Given this list of marker genes TBC1D13, RRM2B, RUNX2, ANXA1, SYF2, VNN1, MAN1A2, MOB1B, RPS6KA2, TOLLIP, MMP14, PCARE, TSSK2, CAPN5, GPR155, P2RY14, BLOC1S4, SPTSSB, PMPCB, TNNT2, TAP1, ABI1, PAFAH1B1, TRMT112, PKP4, KCNK10, SERTAD1, ITPR1, RGL1, TANC1, FAM107B, LYSMD3, PFKP, GSPT1, MDFIC, B2M (NCBI Gene Id 567), CD82, ELOC, CAPZA1, IRF8, DENR, SAMSN1, TNIP2, SHC3 (NCBI Gene Id 53358), MYO1D, ADRB3, MTARC2, ATOSB, SPRYD7 (NCBI Gene Id 65073), FAM91A1, KAT2B, IFNAR2, MYD88, BIRC3, RILPL1, UBE2N, MTMR14, NAT2 (NCBI Gene Id 10), ATXN7L1, RAB3IP, SLF2, TSHZ1, TCP10L, SOD2, PCP4, C5orf15, DHX58, STXBP1, BRAF, JAM3, TRAF4, NDEL1, SENP6 (NCBI Gene Id 26054), SLPI, IREB2, RNF214, DUSP2, NRG3, DHPS, ALOX12, IL1RAP, SRD5A2, CGGBP1, SPTLC2, HTRA2, ASB3, MMP2, VPS54, IGF2BP1, FGL2, MSN, HMOX1, ILF3, MAGED1, WBP4, PRG4, CRIPTO, SLAMF1, RBM43, SHROOM1 (NCBI Gene Id 134549), APBB1IP, SLC40A1, USP26, SLC2A5, TRPC4AP, CARD10, POU6F1, GKAP1, BMPR1A, ZBTB37, STARD5, SLC37A3, SNX16, ATM, BST2, ADAMTS8, CHRAC1, TMEM229B, ADNP, EPGN, TENT2, FGL1 (fibrinogen like 1), PTPRA, TMEFF1, PDK3, PRPF38A, SORCS2, TMED7, SLC6A4, DLG5, TP73, WASHC4, SIN3A, GCG, OAZ2, HMGN5, GNA13, SPTB, HES5, METTL6, TNNI1, SLC26A8, DUSP16, EPX (eosinophil peroxidase), MAP3K8, G3BP2, STAT5A, LZTFL1, SPATA4, SOX12, PI4K2A, UBAP1, HIPK1, OPN4, GCA, OAS2, MAP3K5, HDAC1, GBP4, VAMP3, TSC22D1, TAMALIN, C19orf12, LDHC, DCAKD, FIS1, ARNT, GK, WDR43, CMTR1, ATXN7L3, NHERF1, SLC32A1, TMEM192, PHLDB2, SLC17A1, ANXA5, SLAMF8, TAB3, NECTIN2, EPSTI1, TRAF5, CXCL6, CCNA1, INSM1, GSAP, GTPBP2, PPP1CB, SMC5, DDA1, MLLT6, ZNF689, RNF34, AOPEP, ATL3, TMEM175 (transmembrane protein 175), MITF (melanocyte inducing transcription factor), IER5, CPD, here is a description of the gene set: species: Homo sapiens mouse primary BMDCs were stimulated with tlr ligands and gene expression changes were profiled on Affymetrix arrays Human Gene Set: GSE17721_0.5H_VS_8H_LPS_BMDC_DN Genes down-regulated in comparison of dendritic cells (DC) stimulated with LPS (TLR4 agonist) at 0.5 h versus those stimulated at 8 h. from publication Amit I, Garber M, Chevrier N, Leite AP, Donner Y, Eisenhaure T, Guttman M, Grenier JK, Li W, Zuk O, Schubert LA, Birditt B, Shay T, Goren A, Zhang X, Smith Z, Deering R, McDonald RC, Cabili M, Bernstein BE, Rinn JL, Meissner A, Root DE, Hacohen N, Regev A (PMID 19729616)